Given this list of marker genes APOBEC3A, APOBEC3C, APOBEC2, A1CF, APOBEC4, APOBEC3H, APOBEC1, APOBEC3B, here is a description of the gene set: Reactome Pathway: mRNA Editing: C to U Conversion studied in species Homo sapiens The best characterized case of C to U editing is in the intestinal apolipoprotein B transcript, where the editing event creates a premature translation stop codon and consequently leads to a shorter form of the protein. In the liver, C to U editing is important in the expression of specific isoforms of the apolipoprotein B enzyme. ApoB mRNA editing is a posttranscriptional, nuclear process that can be initiated after splicing, at the time of polyadenylation and is completed by the time pre-mRNA matures fully.<BR>This editing event is a simple hydrolytic cytidine deamination to uridine, and is carried out by the Apobec-1 enzyme, along with the Apobec-1 complementing factor, ACF. The editing of apo-B mRNA involves the site-specific deamination of (C6666 to U), which converts codon 2153 from a glutamine codon, CAA, to a premature stop codon, UAA. As ACF is distributed in a variety of tissues, and these genes contain multiple family members, it is possible that editing events in additional targets will be found.<BR>The cis-acting regulatory elements for C to U editing include: 22 nt editing site within ApoB mRNA, 5' tripartite motif with an enhancer element adjacent to the target cytidine, a spacer element and mooring sequence both 3' to the cytidine. part of: mRNA Editing